The following is a description of a gene set: Mouse Gene Set: MIR_483_3P from publication Chen Y, Wang X (PMID 31504780) Genes predicted to be targets of miRBase v22 microRNA mmu_miR_483_3p in miRDB v6.0 with MirTarget v4 prediction scores > 80 (high confidence targets). studied in species Mus musculus, and this is the list of marker genes: Crbn, Kcnj3, Tlk2, Crx, Coa4, Dhrs7b, Cnot6l, Igf1, Gm6812, Rab11fip4, Med1, Marchf10, Rtl5, Coq7, Cops2, Hivep2, Pdp2, Phf20l1, Fut1, Zbtb5, Ino80, Usp32 (NCBI Gene Id 77025), Zfp11, Rbak, Zfp219, Phactr1, Prkar1a, Cd59a, Slc24a1, Cdh4, Mtpap, 1700020N15Rik, Stk10, Phc3, Vezf1, Sanbr, Usp24, Cluh, Nek9, Wdr44, Mfsd8, Cdh9, Uap1, Itga1, Pgam1, Fignl2, Ogt, Dixdc1